The following is a description of a gene set: from publication Chen Y, Wang X (PMID 31504780) Human Gene Set: MIR4303 Genes predicted to be targets of miRBase v22 microRNA hsa-miR-4303 in miRDB v6.0 with MirTarget v4 prediction scores > 80 (high confidence targets). studied in species Homo sapiens, and this is the list of marker genes: HOMER1, MIOS, GID4, POLR2M, NUAK2, RRP8, TFEC, SCN1A, CLEC4E, RAB3C, PPM1B, IL18BP, GCNT3, MYO5B, LRRC20 (leucine rich repeat containing 20), TMEM121B, SURF6 (NCBI Gene Id 96491), HS3ST1, CASK, KRBA1, ALAD, UBXN10, TBX19, SSPN, PAFAH2, NLE1, PTBP2, STON1, YOD1, DNAL1, LRRC28, DCX, FAT4, PDIA3, ZKSCAN8, CYYR1, STX6, OAS2, TRIM33, ZCCHC24 (zinc finger CCHC-type containing 24), APOBEC3A, KIF21A, NAPG, PAX7, RNGTT, MSI2, TARS3, RHOQ, NDUFA5, RSAD1, AGPAT4, ADAMTSL5, AOPEP, PRKCA, ABL2, CRADD, IGF2, ARHGEF12, C12orf42, DERL2, GPC5, FMNL2, FNIP1, RASGRF1, CELF4, SLC44A1, LUZP1, DCLK1, NFATC2, TMEM68, MAFB, KIF1B, EML4 (NCBI Gene Id 54548), MTF1, CARD8, EIF4E3, RNF146, SPCS3 (NCBI Gene Id 60559), SLC49A4, LGR5, ASPHD2, PABPC1, HIP1, MTMR4, RNF14, HIC2, MTCL1, B3GALT5, CTBS, SARM1, ARRDC3, NAP1L5, NCAPH2, MAP6, CNBP, UBASH3B, POMGNT1, CLIC5, CNNM1, C21orf58, ZFR, RB1, RC3H1, STAMBP, CCDC68, CDS2, PEAK1, CNTN1, KCNH6, ACSM5 (NCBI Gene Id 54988), CTDSPL, ERCC6, DLG5, PLXNA4, TMED1, RUNX1, ITGB8, RHOT1, NREP, DDHD1, ARB2A, BNC1, RAB8B, RALGPS2, ZNF571, GALNT1, SPATA31D4, COL4A6, PCYT1A, PLD5, HOXC8 (homeobox C8), ATP6V1A, RAB6B, SLC4A7, CLPB, PDE11A, STN1, GCOM1, SIMC1, NCAM1, VCL, EFCAB14, SPATA31D3, SP1, IL22RA2, ARID2, AGAP1, TREML2, EYA1, MYEOV, FRMPD2, FGF14, ZFYVE9, RAD52, AJUBA, RALGAPB, MYT1L, DBNDD1, RPS6KL1, PACRGL, SRSF9, RBPJ, IKZF2, ACVR2B, LDLRAP1, KCNJ12, KCTD20, CYP4A22, SNX22, COG5, SPTBN1, ADRA1A, RCAN1 (regulator of calcineurin 1), GYPA, SORCS3, PTGER4, PPP1R9A, FAT3, ROBO2, CSTF2, APOL6, GNAQ, CYCS, FCER1G, KDM4B, OLA1, F5, PTCH1, TRAK2, KCNQ3 (potassium voltage-gated channel subfamily Q member 3), EPB41L1, PIAS2, PTPRT, NIT1, ZNF827, AAK1, SPTLC2, VAV3, RBM25, CNOT4, RORC, ZMIZ1, ATP6V1E2, C17orf100, C2CD6, C1orf21, ZNF322, RPE, SPECC1, EIF2B2, CALHM4, CYP4F11, CAMSAP1, ATP2A2, ERCC6L2, KALRN (kalirin RhoGEF kinase), BTBD7 (BTB domain containing 7), UBE2E3, TTC14, PUS7, PTEN, MAPK10 (mitogen-activated protein kinase 10), DR1, PIK3CA, MUC12, ITIH5